The following is a description of a gene set: Genes having at least one occurrence of the motif TGGGGTYACTNNCGGTCA in the regions spanning 4 kb centered on their transcription starting sites. This matches the NR1H3 transcription factor binding site V$LXR_Q3 (v7.4 TRANSFAC). studied in species Homo sapiens Human Gene Set: LXR_Q3, and this is the list of marker genes: RNF213, RASL11B, MAPKAPK3, SLC2A4, APOC1, FOXD3, CIC, PPP4R3A, ASIC1 (NCBI Gene Id 41), KCNQ1DN, HAS2, CYB5R4 (cytochrome b5 reductase 4), ZNF513, SULF1, ACACA, DRD1, ADAM17, PRMT3, LPCAT3 (NCBI Gene Id 10162), PHOX2A, MID1IP1, NRG1, POLA1, BLVRB, KDM2A, CCNI, LYRM1, BRWD3, MAP2K7, SND1, TMPO (NCBI Gene Id 7112), TBC1D10B, GREM1, ACY1, NUAK1 (NUAK family kinase 1), NFKBIA, CDC73, MAFB, NKAIN3, ELAVL3, AMD1, ACSL3, NR5A1, CTCF, ASIC2, C1QC, STAG2, GLI1, ABCA1, RARA, SDCCAG8, ABCG1, SLC38A6, LRP3, JADE2, SPOP, PRKCG, FAM193A, AZI2, ETV4, RNF145, NKX2-1, SGK1, MSI1, DCUN1D3, MITF, SPATA32, NR2E1, HPCAL4, IKZF2, JARID2, SPRY2, CHMP2B, GJD2, PPARD, PTMS, FKBP2, RB1CC1, TAOK2, SPTBN4, RARG, PCSK1N